Given this list of marker genes THAP6, SIM2, SREK1, CPNE1, TRDN, KRAS, UBR5, CCNT2, BPNT2, LMX1A, GPSM2, EGLN1, SKP2, SKIL, C14orf28, METAP1, SERTAD2 (NCBI Gene Id 9792), KLHL28, PCDHB10, FAM200B, SMG1, NCAPD2, TRIQK (NCBI Gene Id 647518), STAU2, C4orf19, PRKACB, GATA2, FOXF1, ZWINT, PCDH11Y, ROBO1, NOTCH2NLA, AKAP7, SLC6A6, EXOC6B, SEC24A, TWF1 (NCBI Gene Id 82712), GUCY1B1, POLR3C, ZNF626, OAZ1, TBCA, LPP (LIM domain containing preferred translocation partner in lipoma), EXOC5, MARCKS, HNF4G (hepatocyte nuclear factor 4 gamma), WNT5A, PROSER1, PURG, PPM1A, BIVM (basic, immunoglobulin-like variable motif containing), C4orf33, FAM135A, KCNK2, CPEB4, TMTC3, CD2AP, SNX2, ZMYM2, NEK7, RUFY2, LRP1B, AGFG1, ANKIB1, CA8, KCNK1, SOX8, ATP10B, SS18, RIMS1, PNISR, THAP1, GPM6A, C9orf72, PSPC1, KCTD5, UBQLN2, UBE2W, SERINC3, SPACA1, CCSER1, SKIDA1, INSM1, HPS3, RAPGEF1, QKI, ZNF681, DISC1, SCML1, TAB3, DENND6A, LAMTOR3, ATRX, PTGR2, YWHAQ, IGF2BP3, APPBP2, RIPOR2, USP44, TEX36, SLAIN2, GPR171, PRKAA2, ZNF99, DIRC1, OMA1, LARP4, CSRNP3, BTG1, ZBTB34, RAB33B, BMPR2, TOLLIP, CDS1, IRF8, CAMK2D, PEX13, ZCCHC8, RYK, FAM76B, GJC1, PHTF1 (putative homeodomain transcription factor 1), HELZ, ASAP2, OTUD1, CACNA2D3, PTPN2, SGTB, GNG12, SYNCRIP, SUMO1, APLF, SACS, PARP12, LATS1, ACSS1, LIN7C, GATM, SEC61A2, CCDC179, STXBP5 (syntaxin binding protein 5), MYLK4, GTF2I, SLC9A2, DPY19L1, DLG3, KDM3B, RANBP3, ANAPC1, IPMK, CD99, EMSY, CHD1, RABL3 (RAB, member of RAS oncogene family like 3), IRF2BP2 (interferon regulatory factor 2 binding protein 2), PPARG, OTUD5, LRRC58, FRMD4A, RIC1, ZBTB41, CLMN, EHHADH, TAOK1, RMND5A, CSNK1G1 (NCBI Gene Id 53944), ALG10B, RPRD1A, RNF2, ZNF608, ERC2, DPP8, MSI2 (musashi RNA binding protein 2), ST8SIA4, LACTB (NCBI Gene Id 84943), ARL6IP6, TRA2B, RNF212, TSPYL6, GPR137C, DOLPP1, DESI2, SNX18, TIAM2 (TIAM Rac1 associated GEF 2), BMI1, UNC5D, UFM1, TMPO, ZNF527, DEPDC4, CCNB1, CSNK2A1, CCT6B, ZKSCAN7, VWC2, FGD4, MAML1, DGKH, TVP23C, MMD, CPS1, RC3H1, RUNX2, TMTC1, XRN1, RHPN2, MEIKIN, APPL1, CFL2, RHOT1, FCGR2B (Fc gamma receptor IIb), MTFR1, EPHA5, MAN1A2, RABGAP1L, SOBP, C21orf91, HDAC4, RBFOX2, MEX3D, PTGES3L (NCBI Gene Id 100885848), VPS13C, PCDH11X, JUND, TMEM181, HOXD13, GTF2H3, U2SURP, PELI1, ELL2, TSNAX, LHX9, ZRANB3, USP6NL, PITX2, CCNG1, SEPTIN2, PIGX, CACNB4, MOB1B, AUTS2, SC5D, RO60, TAL1, DCLK1, XCL2, TUT7, NECTIN3, MAFB, MIER3, C11orf87 (NCBI Gene Id 399947), DCUN1D1, LYVE1, SRCIN1, MATR3, CPNE8, PGAP1 (NCBI Gene Id 80055), PPP1R27, ZIK1, SLC12A5, CREBRF, TPMT, KIN, ERICH3, SQOR, FUBP1, DSCC1, MYLIP, DAAM1, XCL1, RIMOC1, SNW1, HERC1, CDK6, ZBTB6, CYSLTR1, CXCL11, AFTPH, ARL13B, KRIT1, SMARCE1, KATNAL1, SP1, BRIX1, ADAMTS9, TIFAB, NAA30, BBS10, RGS7BP, CCP110, DNAJC21, THSD7A, SLC30A7, ANKRD10, KAT6B, HAUS2, CUL5, CLCC1, CCNJ, ATF6, HNRNPR, KRT28 (NCBI Gene Id 162605), REEP3, FAM221A, LRIG1, ZNF649, ACVR2A, URI1, S100PBP (S100P binding protein), RASGEF1A, DCTN5, CAAP1, GPM6B (NCBI Gene Id 2824), TM9SF3, SOCS6, CTNNB1, MAP3K2, STK35, SLC38A2, RESF1, RAP2A, HOOK3, IFT70A, ZNF737, NFAT5, WDR26, MAP4K5, EPB41L5, ABCB11, SEC23A, STOML3, HLTF, TASOR, AQP3, TBR1, ZNF493, DUS4L, DIS3, FBXO32, IGSF11, ADAM18, ZDHHC21, ZC3H6, ZNF326, LRBA, ZFP91, DYNC1LI2, SLITRK4, MAST3 (NCBI Gene Id 23031), PHTF2, ECHDC1, WAPL, INSIG1, SLC4A4, CNOT6L, NOTCH1, MACROH2A1, BOLL, FLRT3, DEK, KLHL24, HNF1A, DMTF1, PRKAA1, EXPH5, KMT5B, INPP5A, NOL7, UGT8 (NCBI Gene Id 7368), AADAT, IKBIP, KLHL36, SMAD1, SEC22B, TTC13, ATG16L1, SINHCAF, HIP1, PGBD1, NAALADL2, PPIP5K2 (NCBI Gene Id 23262), SEC22A, TP63, MTA1, CACUL1, RAB3C, SNX16, MIGA1, NFKB1, UBE2D3, IVNS1ABP, NABP1, PGAM1, ABI3BP (NCBI Gene Id 79859), TNFSF10 (TNF superfamily member 10), HMBOX1, SLC35D1, TOX3, SCAI, NRXN1, CNTN1, CIMIP6, DCUN1D3, SGIP1, TAF2, TAFA2, UBE2B, EMP1, ETF1, DHRS1, PDCD6IP, DCBLD2, APAF1, LRP8, KDM7A, FAM133B, DCT (dopachrome tautomerase), CENPA, LINC01517, N4BP2, AK3, ZIM3, VEZT, LY75, TRIM33, SLCO1A2, ARK2N, PRPF39, TMEFF2, CTNNA3, BRWD3, NCOR1, ODAPH, PCDH10, NUP54, LANCL1, ATAD2, ARHGAP29, TNRC6B, CDKL5, EGR2, TMOD2, UNC45B, ATXN2L, PCDH20, ERO1B, TENT4B, SAR1B, PPEF2, E2F4, DNAL1, ZNRF2 (zinc and ring finger 2), RSAD2, PTPRG, AICDA, TBL1XR1, CDH17, MAP3K20, CAPN2, NEGR1, TLCD4, CHIC2, PPIC, SYCP2, ZNF106, VGLL3, LRRN1, PLAG1, ZDHHC15, ERLIN2, HACE1, PDE4D, CXCL5, ZEB2 (NCBI Gene Id 9839), ERBIN, BCOR (BCL6 corepressor), BICC1, KPNA1, GPD1L, EEA1, IFNL1, SRSF6, RPGRIP1L, SMIM13, FAM199X, RIOX2, SMC5, TCEAL8, SGCZ (NCBI Gene Id 137868), HS2ST1, ABCA8, VIRMA, CHIC1, ZNF800, TUSC1, PCGF3, ZFR, IKZF2, TXNDC15 (thioredoxin domain containing 15), EMCN, RYBP, SOX6, PKN2, FMO2, GPD2, B3GALT2, IAPP, SELENOI, RRAS2 (RAS related 2), CTNND1, OSBPL8, BRWD1, RNF41, ZNF711, MZT1, TRPC1, MICU3, USP12, STAG2, ANGPTL1, PDLIM5, TRIM58, ADAM22, GABPA, UBR3, RAB27B, POLR2H, HDAC9, ELOA, KLF9, ZNF813, VIM, DCDC2, SLAIN1 (NCBI Gene Id 122060), CHSY3, STRBP, MAPK1, FGF5, RAB7A, HIVEP2, REV3L, PAPOLA, SIX4, GLIPR1, RACGAP1, ARIH1, PRKCA, NUDCD1, DSC3, COL12A1, ZFHX4, GNPTAB (NCBI Gene Id 79158), MARCKSL1, INTS6, CELF3, FOXG1, MAP4K3, CABCOCO1, INSR, SPHKAP, MAF, PHC3, UTP3, MEGF11, ITPRID2, RAB31, SUPT7L (SPT7 like, STAGA complex subunit gamma), CREB5, PAK5, CLASP2, PROK2, CXADR, KITLG, ARPP19, SERBP1 (NCBI Gene Id 51624), SAV1, PRDM10, HCN1, BCL2L2, MGAT4A, CFDP1, SEMA3C (semaphorin 3C), GPR137B, ZNF652, ROBO2, MBOAT2, COMMD3-BMI1, SEC23B, MAGT1, PPFIA1, MEF2C, NLK, FMN2, YLPM1, KCNC2, ICE2, DCUN1D5 (defective in cullin neddylation 1 domain containing 5), LRRC42, FAIM, DYNC1I2, PTBP3, CHST9, PAIP1, ZNF345, SULF1, ZNF492, ERLEC1, BMP3, PLAGL2, SH3BGRL (NCBI Gene Id 96022), CCDC88A, ZNF100, RGS2, C5orf24, CD84, DNAJB4, B4GALT6, here is a description of the gene set: from publication Chen Y, Wang X (PMID 31504780) Genes predicted to be targets of miRBase v22 microRNA hsa-miR-548n in miRDB v6.0 with MirTarget v4 prediction scores > 80 (high confidence targets). Human Gene Set: MIR548N species: Homo sapiens